Given this list of marker genes Gm4751, Pex1, Gm24686, Gm8929, Gm5715, Abcb1b, Gm40264, Tubb4b-ps1, Gm4128, Gm4959, Speer1f, Gm15731, Gm32554, Gm24666, Speer1a (spermatogenesis associated glutamate (E)-rich protein 1A), Slc25a40, Mterf1a, Dbf4, Speer1d, Gm35702, Speer1b, Gm3203, Gm33847, Gm23312, Gm7332, Grm3, Gm33093, 2510017J16Rik, Gm3053, Gm43132, Gm10481, Speer1i, 4833413G10Rik, Gm3321, Gm43358, 4930558F17Rik, Gm18985, Gm42580, Tmem243, Zfp804b, Gm22897, Steap4, Gm32877, 1700108N06Rik, Gm21759, Cldn12, Speer1c, Gm35212, 4930437M23Rik, Gm15459 (NCBI Gene Id 727711), Dmtf1, Gm15610, Rundc3b, Gm31831, Gm8891, Gm30835, Rps4x-ps, Gm6650, Dnd1-ps, Cyp51, Speer1n, Gm15772, Gm10484, 1700003C15Rik, Gm42744, Mterf1b, Wdr46-ps, Gm4960, Gm29745, Gm6465, Abcb4, Gtpbp10, Cdk14, Gm10108, Gm23993, Gm8874, Speer1h, Gm17590, Crot, Speer1j, Gm17936, 1700109H08Rik, Akap9, Gm8924, Gm8953, Cfap69, Cdk6, Gm28685, Pttg1ip2, Gm6455, Adam22, Gm24525, Speer1e, Gm5714, Gm23838, Rbm48, Sema3a, Gm42834, Speer1g, Gm3360, Ankib1, Gm8896, 7330423F06Rik, Mir879, Fzd1, Gm15730 (NCBI Gene Id 433840), Gm5106, Tex47, Gm10482, Gm8706, Gm6586, Gm21040, Gm3027, Fam133b, Gm8802, Gm29755, Krit1, Sema3e, 4930568A13Rik, Gm15750, Gm43131, V1rg10, Gm18187, Speer1k, Gm36548, Gm6647, Speer3, Sri, Abcb1a, Gm8715, Steap1, Gm8861, Lrrd1, Gm6641, Tmbim7, Gm30652, Speer1m, Gm6486, Gatad1, Gm38697, Sema3d (NCBI Gene Id 74345), Pclo, Gm8968, Steap2, Gm8920, Gm40263, Gm8925, Gm5288, Elapor2, Fam237b, here is a description of the gene set: studied in species Mus musculus Mouse Gene Set: chr5A1